The following is a description of a gene set: The gene expression profile of the aging process was analyzed in skeletal muscle of mice. Use of high-density oligonucleotide arrays representing genes revealed that aging resulted in a differential gene expression pattern indicative of a marked stress response and lower expression of metabolic and biosynthetic genes. Most alterations were either completely or partially prevented by caloric restriction, the only intervention known to retard aging in mammals. Transcriptional patterns of calorie-restricted animals suggest that caloric restriction retards the aging process by causing a metabolic shift toward increased protein turnover and decreased macromolecular damage. Human Gene Set: LEE_CALORIE_RESTRICTION_MUSCLE_UP Up-regulated in the gastrocnemius muscle of aged (30-month) mice subjected to caloric restriction diet since young adulthood. from publication Lee CK, Klopp RG, Weindruch R, Prolla TA (PMID 10464095) species: Mus musculus, and this is the list of marker genes: PRKCSH, FABP5, PSMC3, THBD, GIP, FZD6, CTNNA1, MYBPH, CRYGD, DDIT3, CYP2C8, PEX5, ATP1A2, ALDOC, SLC1A5, NPY4R, CLTB, PLIN2, MYH7, GLUL, PNP, ACTC1, SSR4, EEF1G, PPARD, PSMB7, ADIPOQ, TKT, ACTB, FASN, CMPK2, NDN (necdin, MAGE family member), GPD1, PPARG, PPP1R2, LTA, FBP2 (NCBI Gene Id 8789), CA4, PSME1, GUCA1ANB-GUCA1A